Given this list of marker genes TMEM106A, SPIC, FOS, MIF, TMEM183A, IFRD2 (interferon related developmental regulator 2), ASS1, MVP, CCR7, NT5C3A, LCN2, SPRED1, ZBTB25, HP, ANXA7, STIP1, IRGM, LGALS3BP, UBA7, UBAP2L, RRS1, ALAS1, CD274, DDX24, SLAMF8, MAN2A1, CXCL6, PUS7, AIDA, EIF2S1, SOS1, LAPTM4B, SELL, DHX58, TNFAIP3, BYSL, ZNFX1, CLIC4, TREM1, AOAH, CLEC4D, UBE2F, PSMB9, JAK3, PLXNA2, TOR3A, UPP1, PNPT1, IFIT1B, TUBB6, KLRK1, CCT6A, KCNE4, IFIT3, IRF7 (NCBI Gene Id 3665), PSMB10, ST6GALNAC4, CSTB, CTTNBP2NL, TRDMT1, NMI, TBRG1, OAS2, LTB4R, MOV10, FTH1, ST13, TMEM140, PROCR, RAB20, AKT3, IFIT2, OGFR, CXCL9, TNF, TOR1AIP2, FPR1, HCAR2, NOC4L, IFI44, LGALS9B, BATF, USP18, HK1, MAPK6, RNF114, DDHD1, TMEM39A, TIFA, F11R, FBXO6, CACNB3 (calcium voltage-gated channel auxiliary subunit beta 3), TAPBP, CASP4 (caspase 4), BST1, EEF1E1, RCL1, FCER1G, OAS1, ZBP1, GNG12, CLUH, NFKBIZ (NCBI Gene Id 64332), SOWAHC, TMEM11, MITD1, CDKN1A, DDX60, PRKCD, RELB, MYC, CARS1, NAA20, SCT, CXCL16, NTS, TAPBPL, GK, VMP1, PNP, TSPAN3, CMPK2, NR1H3, TAP1, MRPL17, S100A9, STAT1, SUSD6, LYAR, IFI35, CNBD2, RABGGTB, FLNB, ASPRV1, MMP8, NFKBIE (NCBI Gene Id 4794), GNB4, TNFRSF21 (TNF receptor superfamily member 21), FPR2, SAP30, CLEC6A, SNX10, CD86, PHB1, ITGA5, CD40, TRAFD1, TOMM70, TAP2, LIPG, LRG1, SOCS3, CFLAR (CASP8 and FADD like apoptosis regulator), PARP14, USB1, MARCKSL1, RSAD2, FGR, APOD, PTPN12, OASL, SOCS1, MARCHF5, SRM, KLF6, PSMB8, UBE2L6, CYBB, LIMA1, CCRL2 (NCBI Gene Id 9034), CCL5, WARS1, KPNA3, SDCBP2, SAMSN1 (SAM domain, SH3 domain and nuclear localization signals 1), EIF2S2, UBE2D3, MEFV (NCBI Gene Id 4210), HCK, THEMIS2, C19orf12, LAMP2, SSU72, TRIOBP, STAT2, HAT1, CHI3L1, GBP7, IL15, TINAGL1, RRP12, TIMM10, ZNF397, CTSC, S100A8, HDC, RGS1, SLFN12L, DRAM1 (DNA damage regulated autophagy modulator 1), TIMP1, here is a description of the gene set: species: Homo sapiens Genes down-regulated in thymus cortical regions: subcapsular versus central cortical. from publication Griffith AV, Fallahi M, Nakase H, Gosink M, Young B, Petrie HT (PMID 20064453) Interaction of hematopoietic progenitors with the thymic stromal microenvironment induces them to proliferate, adopt the T cell fate, and asymmetrically diverge into multiple T lineages. Progenitors at various developmental stages are stratified among different regions of the thymus, implying that the corresponding microenvironments differ from one another, and provide unique sets of signals to progenitors migrating between them. The nature of these differences remains undefined. Here we use novel physical and computational approaches to characterize these stromal subregions, distinguishing gene expression in microdissected tissues from that of their lymphoid constituents. Using this approach, we comprehensively map gene expression in functionally distinct stromal microenvironments, and identify clusters of genes that define each region. Quite unexpectedly, we find that the central cortex lacks distinctive features of its own, and instead appears to function by sequestering unique microenvironments found at the cortical extremities, and modulating the relative proximity of progenitors moving between them. Human Gene Set: GSE18281_SUBCAPSULAR_VS_CENTRAL_CORTICAL_REGION_OF_THYMUS_DN